The following is a description of a gene set: from publication Gao S, Yan L, Wang R, Li J, Yong J, Zhou X, Wei Y, Wu X, Wang X, Fan X, Yan J, Zhi X, Gao Y, Guo H, Jin X, Wang W, Mao Y, Wang F, Wen L, Fu W, Ge H, Qiao J, Tang F (PMID 29802404) Human Gene Set: GAO_SMALL_INTESTINE_24W_C7_SECRETORY_PROGENITOR studied in species Homo sapiens, and this is the list of marker genes: LINC00368, EPHA10, FOXD2, ADAMTS16, POU2AF1, KCNT2, OR4N3P, CCDC146, TBC1D22A-AS1, GAD2, ZNF385B, GABRB2, EZH1, TCEANC2, COL9A3, KCNQ2, CIP2A, BCAM, CC2D2A, HTR1D, MX1, PTPN13, LINC01289, LAMA1, LINC00299, ENSG00000280552, FADS6, H1-10-AS1, SV2B, LINC00639, KIF1A, LINC02903, CACNB4, BANK1, SYT16, RASAL2-AS1, GLIS3, ZNF662 (NCBI Gene Id 389114), ABCA7, HCN1, ZNF23, CHD5, EVC2, TMEM201, SRPX2, CHM, GNAO1, LHX9, OGFRL1, AMER3 (NCBI Gene Id 205147), CSN2, C12orf71